Given this list of marker genes LHX1, PAX8, STAT1, PROM1, CD24, WWTR1, PAX2, MEF2C, CTNNB1, OSR1, LIF, GATA3, MTSS1, YAP1, here is a description of the gene set: Human Gene Set: GOBP_NEPHRON_TUBULE_EPITHELIAL_CELL_DIFFERENTIATION species: Homo sapiens The process in which relatively unspecialized cells acquire specialized structural and/or functional features that characterize the cells of the nephron tubule as it progresses from its formation to the mature state.